Given this list of marker genes ENAM, RSPO2, TGFB1, FAM20C, ANKRD11, EDAR, TCIRG1, DMP1, TBX1, TNFRSF11B, MSX2, ODAPH, FOXI3, ITGB6, DSPP, HDAC2, CNNM4, BSG, FOXC1, CTNNA1, DLX2, GLI2, SLC4A2, TP63 (NCBI Gene Id 8860), AMELX, BAX, FST, BMP4, SMO, SMPD3, SOSTDC1, MSX1, AMELY, DLX1, ACVR2B, CSF3R, RELT, BCL11B, FAM20A, RUNX2, EDA, AMTN, SHH, DMRT3, ACVR2A, BCL2L11, HAND1, ROGDI, PDGFRA, LAMA5, TRAF6 (NCBI Gene Id 7189), SERPINE1, APCDD1, CTNNB1, NKX2-3, HAND2, LRP4, GLI3, TNC, FGF10, SCN10A, MMP20, BMP2, KLK4, NECTIN1, CSF1, SLC24A4, NGFR, WNT10A, FGF8, SLC34A1, WNT6 (NCBI Gene Id 7475), LEF1, ODAM, AMBN, CFTR, STIM1, NFIC, HDAC1, PPARA, BMP7, DLX3, JAG2, FGF4, BMPR1A, KLK5, NF2, SCN5A, PERP (p53 apoptosis effector related to PMP22), here is a description of the gene set: The process whose specific outcome is the progression of a dentin-containing tooth over time, from its formation to the mature structure. A dentin-containing tooth is a hard, bony organ borne on the jaw or other bone of a vertebrate, and is composed mainly of dentin, a dense calcified substance, covered by a layer of enamel. Human Gene Set: GOBP_ODONTOGENESIS_OF_DENTIN_CONTAINING_TOOTH species: Homo sapiens